The following is a description of a gene set: Human Gene Set: GOBP_AMELOGENESIS studied in species Homo sapiens The process whose specific outcome is the formation of tooth enamel, occurring in two stages: secretory stage and maturation stage., and this is the list of marker genes: FAM20A, TCIRG1, ROGDI, TGFB1, RELT, DMP1, PPARA, ENAM, NECTIN1, FAM20C, ITGB6, AMELX, STIM1, AMELY, CSF3R, CFTR, KLK4, ODAPH, TBX1, SLC24A4 (solute carrier family 24 member 4, NCBI Gene Id 56796), PERP, KLK5, SLC4A2, AMTN, MSX2, MMP20 (matrix metallopeptidase 20), CNNM4